The following is a description of a gene set: species: Mus musculus This event has been computationally inferred from an event that has been demonstrated in another species.<p>The inference is based on the homology mapping from PANTHER. Briefly, reactions for which all involved PhysicalEntities (in input, output and catalyst) have a mapped orthologue/paralogue (for complexes at least 75% of components must have a mapping) are inferred to the other species. part of: RHO GTPase cycle Reactome Pathway: CDC42 GTPase cycle electronically inferred by orthology from the curated human pathway, and this is the list of marker genes: Dlc1, Arhgap44, Arhgef10, Tagap, Arhgdib, Gna13, Arhgap26, Racgap1, Fgd1, Arhgap45, Cdc42, Arhgap22, Arhgap17, Arap1, Ophn1, Arhgap10, Prex1, Arhgap33, Arhgap40, Arhgef12, Ktn1, Arhgap42, Arhgef15, Fgd2, Itsn1 (intersectin 1 (SH3 domain protein 1A)), Farp1, Fam13b, Arhgdig, Dock11, Cav1, Gmip, Lbr, Plekhg3, Stard13, Ngef, Dock8, Dnmbp, Stard8, Arhgap9, Pik3r2, Depdc1b